Given this list of marker genes Oas2, Rrp1, Tmsb10, Ifi206, Eif1ad (eukaryotic translation initiation factor 1A domain containing), Zup1, Cct8, Nfkbie, Dph5, Smyd5, Npm1, Tkt, Psmb10, Utp14a, Phf11d, Capza2, Irf9, Cdk4, Stat2, H2-T22, Arf4, Mphosph10, Gmppb, Tcstv4, Itm2b, Larp1, Icam1, Dnaja1, Naa20, Pum3, Cxcl10, Alkbh1, Tbrg1, Ppan, Ccnd2, Znfx1, Phip, Napsa, Grn, Cep57, Eif4a1, Ddx60, Tomm40, Ubb (ubiquitin B), Set, Polr1a, Cox5a, Anp32b, Exosc1, Ly6a, Txnl4a, Evi2a, Tmbim6, Slfn2, Lsm12, Pole4, Arhgap30, Timm8a1, Cd47, Serpina3g, Trim12a, Tars1, Serbp1, Brix1, Ndufa12, Hmgn3, Pa2g4, Plac8, Utp15, Ifit3b, Atic, Ythdf2, Psma4, Slamf7, Ndufab1, Tomm70a, Ptges3 (prostaglandin E synthase 3), Aars1, Phf11a, Polr2c (polymerase (RNA) II (DNA directed) polypeptide C), Irf8, Grwd1, Hnrnpd, Pdia3, Tent5a, Nmi, Taldo1, Cd164, Psma3 (proteasome subunit alpha 3), Psmb5, Snrpd1, Cacybp, Epsti1, Trim30c, Atp5pf, Ran, Asb13, Ly6e, Cmpk2, Pdia4, Nip7, Oasl2, Mycbp2, Bop1, Nop10, Polr2f, Casp8, Psmb6, Eif2s1, Ftsj3 (NCBI Gene Id 97720), Ppid, Mrpl54, Nopchap1, Nr2c2ap, Psme2, Ppia, Ppa1 (pyrophosphatase (inorganic) 1), Alyref, Rbm8a, Cxcr5, Snrpf, Igtp, Mrps18b, Lsm6, Nudt5 (nudix hydrolase 5), Rrs1, Prmt7, Rsl24d1, Nampt, Hsp90ab1, Timm9, Selenow, Hspd1, Parp11, Mrto4, Gps1, Isg20, B2m, Unc93b1, St6galnac4, Trim30d, Aimp2, Lap3, Lars1, Rabepk, Dnajc7, Vars1, Nsd3, Ppig, Ctss, Cct5, Ms4a4c, Usp18, Mitd1, Ifit1bl1, Utp23, Cnot6l, Magoh, Stx16, Hspe1, Pcgf5, Naa25, Xaf1, Psmc5, Ybx1, Lgals9 (lectin, galactose binding, soluble 9), Dbnl, Myc, Tap2, Hsh2d, Eif5b, Cd2ap, Tapbpl, Apobec1, Pak1ip1, Sidt1, Cybb, Ranbp1, Gbp7, Parp10, Gadd45gip1, Rnf114, Mrpl30, Usp25, Hck, Mrpl23, Rheb, C1qbp, Ascc3 (activating signal cointegrator 1 complex subunit 3), Pgam1 (NCBI Gene Id 68006), Hspa9, Dtx3l, Mettl16, Eif1a, Rfc3, Helz2, Mrpl12, Mif, H2-T24, Psmb2, Snrpd3, Gtpbp4, Setdb2, Psme3, Mrpl15, Cct4, Tsr1, Polr1f, Ankib1, Uba7, Jaml, Treml2, Mid1 (midline 1), Uvrag, Rasa4, Cycs, Mettl1, Nolc1, Sub1, Srsf2, Nop56, Ldha, Sdad1, Hsp90aa1, Carmil1, Eif3d, B4galt5, Manf, Samd9l, Dek, Tpst1, Nop16, Ssrp1, Lax1, Mybbp1a, Sell, Rcc2, Smchd1, Eif2s2, Hnrnpf, Snx2, Ahsa1, Psma7, Trim30b, Zbp1, Nono (non-POU-domain-containing, octamer binding protein), Erap1, Ruvbl2, Ube2l6, Trim14, Max, Ptma, Eif3a, Gars1, Lpxn, Xrn2, Eef1e1, Tmem33, Mvb12a (multivesicular body subunit 12A), Ly6c2, Cdv3, Fkbp4, Hmox2, Svbp (NCBI Gene Id 69216), Kctd14, Ddx39a, Glrx3, Gbp9, Nop58, Aurkaip1, Nt5c3, Ltv1, Eif4a3, Trafd1, Mndal, Tmem243, Rad23a, Impdh2, Cnp, Yrdc, Nufip1, Bbx, Pole3, Ifi203, Etf1, Ddx18, Eif3c, Ifih1, Slfn1, Ifi213, Srsf3, Mpeg1, Slfn5, Clec2d, Cct7, Sdc3, Acsl5, Zfp593, Tlr7, Mx1, Nup210, Rpf2, H2-K1, Irgm1, Rrp9, Casp4, Rbm4b, Psme1, Atp5f1b, 9930111J21Rik2, Uqcrq, Tspo, Psmb8, Oas3, Cflar, Hsph1, Pes1, Snrpb, Psmc4, Heatr1, Rae1, Rtp4, Tap1, Bst2, Ncl, Nifk, Txn2, Pus1, Ipo5, Samm50 (SAMM50 sorting and assembly machinery component), Tmed5, Eif2ak2, Pnpla2, Timm10, Nob1, Hspa8, Psmg4, Cnn3, Fbl, Trim25, Ubald2, Chmp4b, Parp14, Sp110, Ndufs6 (NCBI Gene Id 407785), Ewsr1, Lsg1, Oas1a, Ifi47 (interferon gamma inducible protein 47), Igkc, Ssbp1, Ifit1, Rsrc2, Cd86, Gar1 (NCBI Gene Id 99602), G3bp1, Rsl1d1, Rcl1, Pgd, Trim12c, Slfn8, Laptm4a, Pno1, Ndufaf4, Tapbp, Trmt1, Ppp1r14b, Ifi35, Chordc1, Uqcc2, Hspa5, Drap1, BC051226, Shmt2, Psmb9, Marchf5, Dhx58, Pcbp1, Eif3g, Lgals3bp, Stat1, Sinhcaf, Sdhb, Rab5c, Snrpe, Rsad2, Dpp4, Bag1, Dkc1, Apex1, Cbfa2t3, Bcap29, Wdr43, Pfdn2, Sar1a, Etnk1, Gspt1 (G1 to S phase transition 1), Rrp7a, Rbm3, Cops7a, Uchl5, Ifi214, Pmpcb, Eif5a, Llph, Pml, Ssb, Tmem184b, Ly86 (lymphocyte antigen 86), Ifit3, Runx3, Atp5mc1, Ppp2r2a, Ruvbl1, Gbp2, Gls, Socs1, Emc6, Odc1, Aen, Pkib, Phb1 (NCBI Gene Id 18673), Tcof1, Gadd45b, Zeb2, Phgdh, Trim30a, Gnl3, Mrps36, Baz1a, Pebp1, Exosc2, U2af1, Mrgbp, Cd38, Aprt, Daxx, Mrpl38, Dph3, Stoml2, Vps37b, Shisa5, Eif4e, Rbx1, Wars1, Adar, Itpr1, Stip1, Nars1, Plaat3, Ebna1bp2 (EBNA1 binding protein 2), Ddx24, Hnrnpdl, Eif3b, Mthfd2, Slc25a5, Cnbp, Sp140, Psma2, Fam3c, Eif3m (NCBI Gene Id 98503), Sp100, Isg15, Sf3b3, Mrps28, Banf1, Snu13, Arfgef1, Nme1, Rtf1, Znrd2, Atm, Rrp15, H2-T23, Ddx21, Lyar, Dnaja2, Ifi209, Parp9, Morc3, Clic4, Irf7, Srsf6, Ms4a4b, Rigi, Tor3a, Nudc, Nit2 (NCBI Gene Id 66227), Cd69, Ogfr (NCBI Gene Id 72075), Aida, Trp53 (transformation related protein 53), Fxr1, Nmral1, St13, Cct3, Zc3hav1, Utp18, Tomm20, Ifit2, Snhg12, Prmt1, Herc6, Ifitm3, Nlrc5, Srsf7, Rnf213, Gbp4, Dhps, Mrpl19, Gpatch4, Tcp1, Calhm6, Ddx39b, Idh3a, Psma5, Cct2, Ybx3, Ifi208, Oasl1, Mat2a, Coro2a, Ywhaq, Nsun2, Atad3a, Ffar1, Srm, Fkbp2, Phf11b, Psmb3, Ogfrl1, Bccip, Samhd1, Ifi27l2a, Nhp2, Tma16, Noc2l, Hnrnpab, Pals2 (NCBI Gene Id 56524), Tor1aip1, Snrpa1, here is a description of the gene set: Genes positively differentially expressed in cell type: B cell upon treatment with cytokine: IFN-α1 in mouse lymph nodes in vivo. Cytokines mediate cell-cell communication in the immune system and represent important therapeutic targets. A myriad of studies have highlighted their central role in immune function, yet we lack a global view of the cellular responses of each immune cell type to each cytokine. To address this gap, the authors created the Immune Dictionary, a compendium of single-cell transcriptomic profiles of more than 17 immune cell types in response to each of 86 cytokines (>1,400 cytokine-cell type combinations) in mouse lymph nodes in vivo. A cytokine-centric view of the dictionary revealed that most cytokines induce highly cell-type-specific responses. For example, the inflammatory cytokine interleukin-1β induces distinct gene programmes in almost every cell type. A cell-type-centric view of the dictionary identified more than 66 cytokine-driven cellular polarization states across immune cell types, including previously uncharacterized states such as an interleukin-18-induced polyfunctional natural killer cell state. studied in species Mus musculus Mouse Gene Set: CUI_B_CELL_IFNA1_RESPONSE_UP from publication Cui A, Huang T, Li S, Ma A, Pérez JL, Sander C, Keskin DB, Wu CJ, Fraenkel E, Hacohen N (PMID 38057668)